The following is a description of a gene set: species: Mus musculus The multiplication or reproduction of blood vessel endothelial cells, resulting in the expansion of a cell population. Mouse Gene Set: GOBP_VASCULAR_ENDOTHELIAL_CELL_PROLIFERATION, and this is the list of marker genes: Aldh1a2 (aldehyde dehydrogenase family 1, subfamily A2), Ccl12, Fgf2, Adam17, Mef2c, Prok1, Dicer1, Pparg, Igf2, Tsc2, Fgfr1, Igf1, Nrarp, Plcg1, Sirt6, Dbh, Slc39a9, Hmgb1, Stat3, Dlk1 (delta like non-canonical Notch ligand 1), Itga4, Sp1, Pdpk1 (3-phosphoinositide dependent protein kinase 1), Tgfbr1, Col18a1, Ghrl, Enpep, Akt3, Apln, Mdk, Flt1 (FMS-like tyrosine kinase 1), Col4a3, Ghsr